Given this list of marker genes RIC1, TNFRSF1A, ADTRP, TNFRSF1B, BMP2, IER3IP1, NOTCH1, RGCC, here is a description of the gene set: Any process that modulates the rate, frequency, or extent of the controlled release of molecules that form the extracellular matrix, including carbohydrates and glycoproteins by a cell or a group of cells. Human Gene Set: GOBP_REGULATION_OF_EXTRACELLULAR_MATRIX_CONSTITUENT_SECRETION species: Homo sapiens